Given this list of marker genes JMJD6, ISG15, ABCA3, HDAC6, VPS35, BCL11A, TRIM65, EP300, here is a description of the gene set: Any process that modulates the frequency, rate or extent of protein oligomerization. Human Gene Set: GOBP_REGULATION_OF_PROTEIN_OLIGOMERIZATION species: Homo sapiens